Given this list of marker genes Hapln1, Jchain, Arx (aristaless related homeobox), Crlf3, Papolg, Fgf13, Msr1, Kif3c, Atp6v1a, Invs, Gls, Nampt, Plpp3, Ube3a, Tfpi2, Ccdc102a, Insig2, Klf6, Atad2, Kcns3, Ripply3, Ranbp3, Ascc3, Btbd1 (BTB domain containing 1), Ubr3, C1d, Spag6l, Faxc, Atp6v0a2, Tmem39a, Dtx4, Usp53, Sp3, 4930447C04Rik, Npy2r (NCBI Gene Id 18167), Ssbp2, Sox21, A1bg, Armc1, Nsg2, Evx2 (NCBI Gene Id 14029), Fsd1l, Dhx8, Htr2c, Rab1a, Cyp2c50, Pgap4, Usp22, Nxf1, Nlgn1, Irak2, Foxc1, Syt6, Chml, Zic4, Zfp715, Sgk1, Brpf3, Nr4a1, Smchd1, Rasgrp1 (NCBI Gene Id 19419), Tmprss11e, Kmt2e, Lmtk2, Wnt5a, Hmgcs1, Bclaf3, Actr6, Dzip3, Chd7, Srsf6, Impa1, Zbtb11, Shprh, Mfap3l, Dlk2, here is a description of the gene set: Genes predicted to be targets of miRBase v22 microRNA mmu_miR_200a_5p in miRDB v6.0 with MirTarget v4 prediction scores > 80 (high confidence targets). from publication Chen Y, Wang X (PMID 31504780) studied in species Mus musculus Mouse Gene Set: MIR_200A_5P